Given this list of marker genes WNT1, LOX, P4HA1, P3H2, ITPR1, P4HA2, P3H1, ADAMTS2, COL1A2, CRTAP, SERPINF1, BMP1, PPIB, SP7, SERPINH1, PLOD1 (NCBI Gene Id 5351), MBTPS2, P4HB (NCBI Gene Id 94756), TNFRSF11A (TNF receptor superfamily member 11a), LRP5, FZD1, TNFRSF11B, CREB3L1, TMEM38B, IFITM5, COLGALT1, TNFSF11, LRP6, MIA3, COL1A1, PLOD2, MBTPS1, FKBP10, here is a description of the gene set: Type I collagen synthesis in the context of osteogenesis imperfecta Human Gene Set: WP_TYPE_I_COLLAGEN_SYNTHESIS_IN_THE_CONTEXT_OF_OSTEOGENESIS_IMPERFECTA studied in species Homo sapiens